The following is a description of a gene set: studied in species Mus musculus Mouse Gene Set: GOCC_RIBONUCLEASE_MRP_COMPLEX A ribonucleoprotein complex that contains an RNA molecule of the snoRNA family, and cleaves the rRNA precursor as part of rRNA transcript processing. It also has other roles: In S. cerevisiae it is involved in cell cycle-regulated degradation of daughter cell-specific mRNAs, while in mammalian cells it also enters the mitochondria and processes RNAs to create RNA primers for DNA replication., and this is the list of marker genes: Rpp30, Rpp38, Pop1, Pop4, Pop5, Rpp40, Pop7, Rpp25, Rpp25l